The following is a description of a gene set: Human Gene Set: chr2p14 studied in species Homo sapiens, and this is the list of marker genes: LINC01829, LINC01805, LINC02831, MIR4434, RNU6-548P, KRT18P33, RPS10P9, VPS54, SNORA74, DNAAF10, RNU6-100P, VDAC2P5, MIR4433B, LGALSL, LINC01812, RN7SL635P, ENSG00000289156 (novel transcript, antisense to CNRIP1and PPP3R1), FBXL12P1, LINC03050, C1D, AFTPH, PELI1, RAB1A, SERTAD2, PNO1, DNMT3AP1, MIR4433A, MEIS1, LINC01828, LINC01873, RN7SL211P, PPP3R1, ACTR2, AFTPH-DT, SLC1A4, PLEK, CEP68 (NCBI Gene Id 23177), LINC02576, RPS15AP15, DNAJB12P1, LINC02245, ENSG00000238012, LINC01628, LINC01800, RPL23AP37, ETAA1, ENSG00000226756, LINC00309, LINC01798, MEIS1-AS3, ENSG00000234255, LINC02934, LGALSL-DT, CNRIP1, LINC01797, PPIAP64, SPRED2, LINC02579, MIR4778, RPL11P1, VTRNA2-2P, MEIS1-AS2, RN7SL341P